Given this list of marker genes AHSP, INHBA, SLC6A9, INHA, ALAS2, EPO, EIF2AK1, ALAS1 (NCBI Gene Id 211), HPX, HIF1A, FECH, AMBP, CAT, LDB1, ABCB10, EPB42, SLC25A37, KLF4 (NCBI Gene Id 9314), PRMT1, here is a description of the gene set: The chemical reactions and pathways involving hemoglobin, including its uptake and utilization. Human Gene Set: GOBP_HEMOGLOBIN_METABOLIC_PROCESS studied in species Homo sapiens